The following is a description of a gene set: species: Homo sapiens Polyuria An increased rate of urine production. Human Gene Set: HP_POLYURIA, and this is the list of marker genes: KCNJ10, CYP24A1, CAV1, CLDN10 (NCBI Gene Id 9071), UMOD, AQP2, SLC34A1, SON, KCNJ1, PTPN22 (protein tyrosine phosphatase non-receptor type 22, NCBI Gene Id 5779), SARS2, SLC12A1, SLC41A1, CLCNKB, KL, SLC5A2, NPHP1, HNF1A, NPHP3, ATP1A1, PAX4, NEK8 (NCBI Gene Id 284086), CASR (calcium sensing receptor), CLDN16, MAGED2, CTNS, BSND, NPHP4, LZTFL1, IL6, BBS2, FAM20A, TMEM67, CLCNKA, SLC12A3, PLVAP (NCBI Gene Id 83483), ITPR3, RRAGD, AVPR2, KCNJ5